Given this list of marker genes Slc7a11, Cd19, Gzf1 (GDNF-inducible zinc finger protein 1), Tbl1xr1, Cacnb4, Rbmx2, Eif4enif1, Lix1, Tmppe, Chac1, Wipf1, Pik3c2b, Mgat3, Dclk1, Zfp111, Foxn3, Cd38, here is a description of the gene set: from publication Chen Y, Wang X (PMID 31504780) studied in species Mus musculus Genes predicted to be targets of miRBase v22 microRNA mmu_miR_540_5p in miRDB v6.0 with MirTarget v4 prediction scores > 80 (high confidence targets). Mouse Gene Set: MIR_540_5P